The following is a description of a gene set: Genes down-regulated in comparison of T follicular helper (Tfh) cells versus Th2 cells. Human Gene Set: GSE11924_TFH_VS_TH2_CD4_TCELL_DN After activation, CD4+ helper T (Th) cells differentiate into distinct effector subsets. Although chemokine (C-X-C motif) receptor 5-expressing T follicular helper (Tfh) cells are important in humoral immunity, their developmental regulation is unclear. Here we show that Tfh cells had a distinct gene expression profile and developed in vivo independently of the Th1 or Th2 cell lineages. Tfh cell generation was regulated by ICOS ligand (ICOSL) expressed on B cells and was dependent on interleukin-21 (IL-21), IL-6, and signal transducer and activator of transcription 3. However, unlike Th17 cells, differentiation of Tfh cells did not require transforming growth factor b (TGF-b) or Th17-specific orphan nuclear receptors RORa and RORg in vivo. Finally, naive T cells activated in vitro in the presence of IL-21 but not TGF-b signaling preferentially acquired Tfh gene expression and promoted germinal-center reactions in vivo. This study thus demonstrates that Tfh is a distinct Th cell lineage. from publication Nurieva RI, Chung Y, Hwang D, Yang XO, Kang HS, Ma L, Wang YH, Watowich SS, Jetten AM, Tian Q, Dong C (PMID 18599325) species: Homo sapiens, and this is the list of marker genes: APLNR, PARK7, CS, PGAM1, FBXL21P, RBMX2, NLGN2, VPS50, OR52N4, CSGALNACT2, BLMH, IFI30 (IFI30 lysosomal thiol reductase), COX6B2, ELAVL4, TNFRSF21 (NCBI Gene Id 51323), GTPBP4, SDHAF3, IMMP2L, GALNS, VAMP7 (NCBI Gene Id 6845), TMEM178A, NEMP1, REPIN1, EXOSC8, PWP2, P2RX4, SLC45A1, PEX2, TEDC2, EPOR, BNIP1, PABPC4, PPAN, AZIN1, BBS12, ARHGEF25, UBA5, MMP15, TSNAX, PNMT, DENND2A, MRS2, LAMC2, IRS4, ATPAF2, CRYBG2, NDUFB11, GGA2 (golgi associated, gamma adaptin ear containing, ARF binding protein 2), CCDC175 (NCBI Gene Id 730656), METAP1, FCF1, DNAJC2, C1GALT1C1, GPN1, CTHRC1, MKRN2, MMP19, SNX5, MCEE, ARHGEF26, ANXA9, GFPT1, SPARC, GTF2E2, PCCA, DOCK10, YTHDF2, UBE2K, PDCD5, PSMC3IP, MCM10, OTOP2, PPP1R1C, NSFL1C, UTP11, HAUS2, TMEM237 (NCBI Gene Id 65062), SNHG12, BUB3, MOAP1, DPYSL4, VXN, TMEM30A, TAMM41, IFRD2, DOCK7, PSMD6, ARID3A, USP1, NSMCE1-DT, PRORP, FAM72A, CEP85, ZNF175, NOP10, TNNC2, ESRRB, MKKS, TMEM132A, GPR135, MFSD12, ADAMTS15 (NCBI Gene Id 219807), NME6, GRID2IP, ACSL5, MRPS18C, VPS29, HCCS, FSTL4, CA12, RCN1, PDZD8, JPH2, GCFC2, C1orf174, B3GALNT2, GMPPB, TMEM190, AMIGO2, ADAM9, SRL, PITHD1, COX6A2, MR1, RCC1, COG6, CIART, RAD51AP1, COL22A1, SEPSECS, RANBP17, ZNRD2, UCK2, DENR, TRIP10, NEMF (NCBI Gene Id 9147), PCMT1, CCT8 (chaperonin containing TCP1 subunit 8), MSANTD4, LSM4, LMAN1L, OR51B6, SAXO2, MECR, AJAP1, HSPE1, SLC4A4 (NCBI Gene Id 8716), CCT6A, ASB1, PEX12 (NCBI Gene Id 5193), ZP2, FOXL1, ABCB6, GAP43, EPCIP (NCBI Gene Id 84761), RPL6 (NCBI Gene Id 6128), TMED2, PLAC8L1, GTF3A, HEMGN, SELP, APRT, RAE1, TMEM219, RSU1, WDR76, CLPTM1L (NCBI Gene Id 81037), DNAAF4, CACNG6, GNE, MTTP, TMEM258, HES2, JPT2, MRPL12, IQCA1, WDR43, RIOK3, MRPL57, PTGER2, KCTD3, RSPO3, GALC, TMEM168, RTN4, PPIL1, ACSL4, TMBIM1, IRAK1BP1, RPE, CANX, POMGNT1, THYN1, YBX2, IRX1, NR2C1, NFYB, ZNF706, RNF113A, AIRE